The following is a description of a gene set: studied in species Homo sapiens Any process that results in a change in state or activity of a cell or an organism (in terms of movement, secretion, enzyme production, gene expression, etc.) as a result of a water deprivation stimulus, prolonged deprivation of water. Human Gene Set: GOBP_RESPONSE_TO_WATER_DEPRIVATION, and this is the list of marker genes: SIPA1 (NCBI Gene Id 6494), UMOD, AQP2, LRP11, AVPR1A